Given this list of marker genes VTCN1, PYGO2, CPNE7, PPA1, HELQ, RSBN1, ARHGAP26 (Rho GTPase activating protein 26), HBG1, GABPB1, APPBP2, C1orf35, ECEL1, ZNF770, MRC2, ZNF146, FAM53B, FAN1, CFDP1, TRIM23, UCHL5 (NCBI Gene Id 82736), STON2, CTSB, EIF4B, NUP88, HEATR6, SRPRB, BRCA2, THOC2 (NCBI Gene Id 57187), ACOT13, HIRA, ABCB10 (NCBI Gene Id 23456), PRMT6, SLC43A3 (solute carrier family 43 member 3), USP8, OR2I1P, SP1, GZMA, THOC1, SERF1A, PFDN4, PPA2, EIF3J, ADAM30, THUMPD1, KGD4, ACTR6, TP53INP1 (tumor protein p53 inducible nuclear protein 1), ADNP2, NUDT16L1, HCN3, PSMD6, L3MBTL2 (L3MBTL histone methyl-lysine binding protein 2), GOLPH3L, HMBS (hydroxymethylbilane synthase), PPM1E, HOMER1, MYH14 (NCBI Gene Id 79784), HNRNPLL, FANCA, NOLC1 (nucleolar and coiled-body phosphoprotein 1), CSDE1, PLEKHF2, TDG, AP4B1, ATAD2B, SULT1A3, ZNF777, ATP5IF1, APC, RAD51C, WNK2, AMH, HNRNPU, HIPK1, ARRB2, here is a description of the gene set: Human Gene Set: MODULE_331 Genes in the cancer module 331. species: Homo sapiens